The following is a description of a gene set: from publication Chen Y, Wang X (PMID 31504780) Mouse Gene Set: MIR_3061_3P studied in species Mus musculus Genes predicted to be targets of miRBase v22 microRNA mmu_miR_3061_3p in miRDB v6.0 with MirTarget v4 prediction scores > 80 (high confidence targets)., and this is the list of marker genes: Zfp930, Inpp4b, Mosmo, Art1, Tktl2, Tgds, Azin1, Tnrc6b, Dnajc28, Clint1, Ddx46, Strbp, Pcid2, Usp25, Slc25a46, Dock7, Srp72, Fdx1, Zbtb43 (zinc finger and BTB domain containing 43), B3galt2, Srsf1, Asph, Pafah1b2, Ascl4, Rgs2, Pik3ca, Il17a, Dock11, Arhgap32, Reep1, Syt16, Phb1, Homer2, Hapln3, Cep57l1, Asf1a, Elf1, Zbtb7c, Rem2 (rad and gem related GTP binding protein 2), Rdh16, Ube2e3, Mtss1, B230219D22Rik, Ptprb, Cntn4, 4930524B15Rik, Tshz3, Ankrd10, Sav1, Pum1, Siah1a, Tmem108, Lclat1, Mex3b, Vmp1, Nsun6, Uty, Zfp493, Smndc1, Map3k2, Mbnl2, Gid4, Snai1 (snail family zinc finger 1), Ugt8a, Lpar4, Ccdc117, Mtcl1, Hsd11b1, Ofd1, Nrn1l, Phc3, Zc3h12c, Gabra4, Cd9, Actbl2, Usp49, Cadm2, Atg4c, Ivns1abp, Vps41, Lmo7, Dpysl2, Onecut2, Chrnb4, Macc1, Cox15, Scn10a, Cpsf6, Hrh1, Sgk3, Vti1b, Rdh9, Mtcl2, Srp54a, Pramel34, Abhd16a, Ctdspl2, Mef2c